Given this list of marker genes SYNCRIP, GPS1, SND1, PES1, IPO5 (importin 5), ASL, SLAIN1, APEX1, CDK2AP1, GALM, YKT6, CTSD, PTH1R, RGS19, UBFD1, JAG2, TMEM97, PRMT1, PDIA3, GOLGA5, PSMD6, ARHGDIA, YBX3, IPO4, EFTUD2, RARS1, SSR2, GORASP2 (NCBI Gene Id 26003), EBNA1BP2, BBLN (bublin coiled coil protein), NHP2, NDE1, LMAN2, COL18A1, SEC61A1, MLEC, SERPINE2, PSMB5, SMYD2, SLC39A7, SMARCA4, MRPS18B, GNPNAT1, TANK, CISD1, MORF4L2, SSR1, RANBP1, PREP, THOP1, UQCC2, RAN (RAN, member RAS oncogene family), NOP16, TUBB6, NUBP1, MRPL20, RAB34, CS, FGF1, WDR74, TUBA1A (NCBI Gene Id 95407), GATAD2A, PTOV1, PDLIM3, EIF4G1, BAX, GALK1, ATF6B, CCT3, TCEA1, SSR3, PKM, PIGQ, SNRPA1, TUBB3, GGA1, DCTPP1, METAP1, NME1 (NCBI Gene Id 7794), PADI2, HNRNPA3 (NCBI Gene Id 220988), PPA1, TMEM147, PSME4, LBHD1 (NCBI Gene Id 79081), PABPC4, DNAJC2, RCN1, DVL3, SEC13, DTYMK, EIF2B5, NARS1, PSMB3, UBE2M, PTP4A3, CLPTM1L (NCBI Gene Id 81037), ERGIC1, VARS1, BANF1, TYMS, NSUN2, TMEM167A, HMGN5, P3H4, ACTA1, UBE2N, MME, PPP1R14B, FKBP11, CARM1, PRELID3B, RPN1, GSTM1, PRRC1, ACOD1, SNRPD3, IRAK1, HDLBP, RWDD1, TPD52, CALCA, FBL (NCBI Gene Id 2091), TMEM14C, MRPL12, C6orf136, TBCB, MRPS10, DDX41, MYDGF, CCT8, CDK4, TOMM70, PSMD1, TCERG1, SERPINH1, SEC61B, SRSF1, ODC1, PDIA4, HTRA2, PKDCC, VCL, here is a description of the gene set: studied in species Mus musculus Human Gene Set: YAO_TEMPORAL_RESPONSE_TO_PROGESTERONE_CLUSTER_14 from publication Yao MW, Lim H, Schust DJ, Choe SE, Farago A, Ding Y, Michaud S, Church GM, Maas RL (PMID 12554760) Human infertility and recurrent pregnancy loss caused by implantation defects are poorly understood. Hoxa-10-deficient female mice have severe infertility and recurrent pregnancy loss due to defective uterine implantation. Gene expression profiling experiments reveal that Hoxa-10 is an important regulator of two critical events in implantation: stromal cell proliferation and local immunosuppression. At the time of implantation, Hoxa-10 mediates the progesterone-stimulated proliferation of uterine stromal cells. Hoxa-10 mutants express a stromal cell proliferation defect that is accompanied by quantitative or spatial alterations in the expression of two cyclin-dependent kinase inhibitor genes, p57 and p15. Hoxa-10 deficiency also leads to a severe local immunological disturbance, characterized by a polyclonal proliferation of T cells, that occurs in place of the normal progesterone-mediated immunosuppression in the periimplantation uterus. Genes co-regulated in uterus during a time course response to progesterone: SOM cluster 14.